The following is a description of a gene set: species: Mus musculus A protein complex that transfers electrons from ubiquinol to cytochrome c and translocates two protons across a membrane. The complex contains a core structure of three catalytic subunits: cytochrome b, the Rieske iron sulfur protein (ISP), and cytochrome c1, which are arranged in an integral membrane-bound dimeric complex; additional subunits are present, and vary among different species. Mouse Gene Set: GOCC_RESPIRATORY_CHAIN_COMPLEX_III, and this is the list of marker genes: mt-Co1, Uqcc3, Uqcrh-ps1, Uqcrq, Uqcr10, Uqcrc1, mt-Cytb, Uqcrfs1, Uqcrb, Uqcr11, Uqcrc2, Uqcrh, Cyc1